The following is a description of a gene set: studied in species Homo sapiens Human Gene Set: GOBP_NEGATIVE_REGULATION_OF_CELLULAR_EXTRAVASATION Any process that stops, prevents, or reduces the frequency, rate, or extent of cellular extravasation., and this is the list of marker genes: CXCL12, CCL25, PTGER4, PLCB1, CCL21, IL27RA, CCL28, MIR146A, BCR